The following is a description of a gene set: species: Homo sapiens Human Gene Set: chr7p15, and this is the list of marker genes: HOXA10, HOXA5, EVX1-AS, CDCA7L, HOXA13, LINC02981, HNRNPA1P73, MIR1183, HOXA6, TPT1P7, HOXA-AS3, CREB5, EIF4HP1, STEAP1B-AS1, IGF2BP3, STK31 (serine/threonine kinase 31), HMGB3P20, SNRPCP19, KLHL7-DT, HOXA4, NPY, NFE2L3 (NCBI Gene Id 9603), SUMO2P14, ENSG00000301703, TSEN15P3, CCDC126 (NCBI Gene Id 90693), IL6-AS1, EVX1, SNX10-AS1, KLHL7, MTCYBP42, MIR196B, SKAP2, LINC02860, RNA5SP228, LINC03007, PCMTD1P3, RPL7AP41 (NCBI Gene Id 392873), RNU6-1103P, CYCS, FAM221A, HYCC1, HNRNPA2B1, SP4, HOXA3, JAZF1, TPM3P4, ASS1P11, ENSG00000202233, NHP2P2, RPL35P4, RN7SL542P, HOXA10-AS, HIBADH, MIR148A, NPVF, ENSG00000257184, HOXA7, ENSG00000228944, FCF1P1, MALSU1, LINC03095, STEAP1B, SNORD65C, RNU7-143P, JAZF1-AS1, CBX3, DNAH11, RAPGEF5, ENSG00000233824, SNX10, HOXA2, CLK2P1, GSDME, HOXA9, AK3P3, TAX1BP1-AS1, RNU6-979P, RNU1-15P, GPNMB, SPMIP4, HOXA-AS2, TRA2A, HOXA11-AS, ENSG00000293754, TAX1BP1, EEF1A1P6, SNORD93, HOXA1, KIAA0087, OSBPL3, NUP42, RPL12P10, TOMM7, HOTAIRM1, SNHG26, IL6, PALS2, RPS2P32, PPIAP80, RPL7AP38, HOTTIP, HOXA11, RNA5SP227, PSMC1P2